The following is a description of a gene set: part of: Developmental Cell Lineages of the Integumentary System species: Homo sapiens <p>Mammals are named for the presence of mammary glands which produce milk, the primary source of nutrition for young mammals. These glands are epidermal structures, evolutionarily considered to be modified sweat (apocrine) glands, with features similar to apocrine glands, and as such represent epidermal appendages. The development of mammary glands is a complex, multi‑stage process that begins during fetal development and continues through puberty, pregnancy, and lactation. Stages of mammary gland development are regulated by hormonal cues and growth factors through a variety of molecular pathways. The primary components of mammary glands are mammary epithelial cells, which differentiate into luminal and myoepithelial cells, and stromal cells that provide structural and physiological support. The key stages of mammary gland development include the formation of mammary buds, ductal elongation, alveolar differentiation, and lactation. This module describes the key cell lineage paths involved in mammary gland development during fetal development, puberty, and lactation in adulthood, focusing on the regulatory roles of estrogen, progesterone, growth factors, and critical signaling pathways like WNT, NOTCH, and Hedgehog. For review, please refer to Howard and Gusterson 2000, Gusterson and Stein 2012, Macias and Hinck 2012, Visvader and Stingl 2014, and Watson and Khaled 2020.</p><p>Mammary gland development begins in the embryo with the formation of the lens‑like mammary placodes around embryonic day 10 (E10) in mice (five pairs). The mammary placode appears as a thickening of the ectoderm and consists largely of epithelial cells. In humans, the first signs of breast development are seen around gestational week GW5, when a 2–4 cell layer mammary line (also known as milk streak or mammary band) appears as a thickening in the ectoderm that extends from the axilla to the groin. The milk line is not visible during mouse mammary gland development. During GW6 and GW7, a thickening in the thoracic region, called the mammary crest, forms a four to six cell‑wide ridge, while the rest of the milk line involutes. Subsequently, mammary crest forms into a nodule that begins sinking into differentiating mesenchyme, forming a flask‑shaped structure, which is accompanied by nipple formation, and followed by the downgrowth of a number of tubes of epithelium into the stroma to form the early major ducts, all together constituting a structure known as the primary bud. The major ducts continue to grow, along with side branches, from the primary bud, developing a lumen and becoming lined by two layers of cuboidal cells. A very large variation in the degree of fetal mammary gland development is observed in neonates, which is probably attributable to differences in maternal hormone level and nutrition.</p><p>In mice, critical molecular signaling pathways active during this stage that ensure the correct placement and early formation of the gland have been characterized in a lot more detail than in humans. Many of the signaling pathways identified in mouse fetal mammary gland development are regulated by paracrine factors secreted by mesenchymal cells that surround the mammary placode. Wnt/β‑catenin signaling is crucial for the initiation of mammary placode formation. Wnt ligands (such as Wnt4 and Wnt10b) bind to their receptors (Frizzled and co‑receptors like LRP5/6), leading to the stabilization and nuclear translocation of β‑catenin (Ctnnb1). Once in the nucleus, β‑catenin interacts with LEF1:TCF transcription factor complexes, driving the expression of genes required for the epithelial thickening and subsequent formation of the mammary placode.</p><p>This module describes four cell developmental lineages of the mammary gland: mammary stem cells, mammary luminal epithelial cells, mammary alveolar cells, and mammary myoepithelial cells.</p><p>The developmental lineage of mammary stem cells (MaSCs) is derived from embryonic non-neural surface ectoderm cells. In the mouse, MaSCs are defined as those cells that are able to generate a functional mammary gland when transplanted in vivo, but there is evidence that mouse MaSCs isolated at different stages of mammary gland morphogenesis are not completely identical. Most data available on human MaSCs is derived from adult stem-like cells in human mammary glands that are able to differentiate in vitro into both myoepithelial and ductal (luminal) epithelial cells and thus are also known as mammary bipotent progenitors (MBiPs), and it is uncertain how much these adult human MaSCs/MBiPs differ from human embryonic and fetal MaSCs.</p><p>The developmental lineage of mammary gland luminal epithelial cells shows two branches of luminal progenitors, the ones committed to the ductal fate and the ones predisposed to the alveolar fate, and development of luminal ductal epithelial cells that line mammary ducts from the former ones.</p><p>The developmental lineage of mammary gland alveolar cells show the differentiation of milk-secreting lactocytes that line the alveoli of the mammary gland, which is initiated during pregnancy.</p><p>The developmental lineage of mammary gland myoepithelial cells shows the development of spindle shaped myoepithelial cells that form the sheath around the mammary ducts and alveoli, contracting in response to oxytocin to enable milk secretion.</p> Reactome Pathway: Developmental Lineages of the Mammary Gland, and this is the list of marker genes: TGFA, FGF10, PRL, AREG, EGF